The following is a description of a gene set: Human Gene Set: WP_1P36_COPY_NUMBER_VARIATION_SYNDROME species: Homo sapiens 1p36 copy number variation syndrome, and this is the list of marker genes: VEGFA, CFAP74, PANK4, DLL1, PLCH2, INTS4, SCNN1D, PUSL1, TNFRSF4, AURKAIP1, TGFB1, CCNL2, KLHL17, VTN, OR4F5, C1orf159, SKI (SKI proto-oncogene), ESR1, MXRA8, TRIM25, CDK11A (NCBI Gene Id 986), TNFSF4, HSPA8, OR4F16, MRPL20, NADK, PEX10, ACAP3, INTS10, MCM2, NOC2L, ANKRD65, RNF223, CD160, DKK3, MORN1, INTS13, PLEKHN1, RER1, SLC35E2B, ELAVL1, C1QTNF12, TNFSF18, BTLA, HES4, PERM1, MEPCE (methylphosphate capping enzyme), GABRD, CALML6, SAMD11, TNFRSF14, INTS11, CUL3, PARD6B (par-6 family cell polarity regulator beta), MMP23B, TMEM88B, MIB2, TAS1R3, ATAD3C, TRAF5, SSU72, ARF6, AGRN, PEX12, FNDC10 (NCBI Gene Id 647347), SDF4, RBX1, PRKCZ, MIR6726, INTS14, IFIT1, MIR6808, METTL14, B3GALT6, CDK11B, MIR1302-2, SMAD4, MUSK, MIR200A, INTS9, SMAD3, HES5, DVL1, MIR200B, COMMD1, LRP4, UBE2J2, MIR6859-1 (microRNA 6859-1), OR4F29, MIR6859-2, GNB1, GRIK2, DLST, ISG15, FAAP20, TNFRSF18, KRT17, PHKG2, MRPL20-AS1, ATAD3B, PEX5, MIR429, CPTP, TMEM52, TRAF2, PEX2, GDE1, MIR6727, VWA1, SMAD2, ATAD3A, IFIH1